The following is a description of a gene set: Mouse Gene Set: GOBP_ARP2_3_COMPLEX_MEDIATED_ACTIN_NUCLEATION studied in species Mus musculus The actin nucleation process in which actin monomers combine to form a new branch on the side of an existing actin filament; mediated by the Arp2/3 protein complex and its interaction with other proteins., and this is the list of marker genes: Ap1ar, Brk1, Gmfg, Washc1, Carmil2, Iqgap2, Actr2, Actr3, Washc3, Hip1r (NCBI Gene Id 29816), Arpc1b, Arpc3, Dnai3, Jmy, Arfip1, Arfip2, Arf1, Wmp, Gmfb, Carmil1, Nckap1, Fchsd2, Wasf1, Gm28729, Rnh1, Whamm, Washc4, Abi2, Wipf3, Wasf3, Washc5, Arpc5, Arpc5l, Arpc2, Wasf2, Carmil3, Magel2, Arpc1a, Washc2, Pick1, Trim27, Cyfip1, Coro1b, Arpc4, Ctnna2